Given this list of marker genes WLS, GBP4, DCLRE1C, SMC5, GFI1, LMTK2, STRN4, LIG4, CBFA2T2, MAFB, PTPRF, BTBD7, MYOF, WAPL, SLC37A2, LCA5 (lebercilin LCA5), ATP10A, PLXDC1, CSNK1E, EIF2AK3, HIVEP3, FBF1, CYFIP2, EFCAB8, DUSP5, ARPP21, PLXDC2, SLC16A5, KCNH2, TLK2, PPTC7, ANKRD6, PRRT1 (proline rich transmembrane protein 1), AFTPH, HSF2, MAGI3, DRC12, NFATC2, MCL1, ALG10B, FAM161B, MIER1 (NCBI Gene Id 57708), RMND5A, MYO10, CAB39, MAP3K8, PPT2 (palmitoyl-protein thioesterase 2), TRPM7, TMEM131, CHD6, NHSL1, CD8B, EVI5L, DUSP4, B3GALT2, TACC1, FOXI1, OSBPL11, TPP2, NTN1 (netrin 1), PTPN7, MYLIP, CBLN4, PLAC8L1, PRODH, VARS2, ATP13A3, PARP11, NFKBIE, XRRA1, DAB2IP, TOLLIP, CBFA2T3, ITGA6, GZF1, RAB11FIP4, PFKFB3, CD6, BMAL1, UTP25, BACH1, PAN3, MTSS1, TBC1D2B, CNOT6, ATAD1, KCNJ13, ARID2 (NCBI Gene Id 57676), CEP85, CRYBA1, HS6ST1, STRN3, PPP1R16B, NRIP1, ARL5C, CBL, PTP4A3, NTRK3, RAI1, TTPAL, CD5, RAB5A, TUBE1, VEZF1, SLC38A1, H6PD, ANXA5, USP42, ITGAV, PCF11, FHIP2A, MIR421, DYRK1B, SOCS1 (NCBI Gene Id 8651), AGFG2, CD2AP, MEF2A, TCOF1, DUSP16, NAV2, TCF12, ARHGAP31, BRD4, ZC3H12C (zinc finger CCCH-type containing 12C), TTC13, MAPKBP1, RRAGD, CIDEB, EGLN3, VAMP1, KMT2E, GTF2IRD1, SEC24B, MED14, RALGDS, SMOC1, P2RX1, PFN2, PYCARD, MBNL2, SLC35D1, HDAC9 (histone deacetylase 9), ICAM2, APOBEC2, PSAP, ID3, ENTPD5, QSER1, RNF157, MAP3K1, BFSP2, DGKG, DNAJC6, TMC8, IL18BP, GRIK2, CEP120, SEMA4D, BACH2, CD247, MCAM, here is a description of the gene set: BACKGROUND: Dendritic cells (DC) play a central role in primary immune responses and become potent stimulators of the adaptive immune response after undergoing the critical process of maturation. Understanding the dynamics of DC maturation would provide key insights into this important process. Time course microarray experiments can provide unique insights into DC maturation dynamics. Replicate experiments are necessary to address the issues of experimental and biological variability. Statistical methods and averaging are often used to identify significant signals. Here a novel strategy for filtering of replicate time course microarray data, which identifies consistent signals between the replicates, is presented and applied to a DC time course microarray experiment. RESULTS: The temporal dynamics of DC maturation were studied by stimulating DC with poly(I:C) and following gene expression at 5 time points from 1 to 24 hours. The novel filtering strategy uses standard statistical and fold change techniques, along with the consistency of replicate temporal profiles, to identify those differentially expressed genes that were consistent in two biological replicate experiments. To address the issue of cluster reproducibility a consensus clustering method, which identifies clusters of genes whose expression varies consistently between replicates, was also developed and applied. Analysis of the resulting clusters revealed many known and novel characteristics of DC maturation, such as the up-regulation of specific immune response pathways. Intriguingly, more genes were down-regulated than up-regulated. Results identify a more comprehensive program of down-regulation, including many genes involved in protein synthesis, metabolism, and housekeeping needed for maintenance of cellular integrity and metabolism. CONCLUSIONS: The new filtering strategy emphasizes the importance of consistent and reproducible results when analyzing microarray data and utilizes consistency between replicate experiments as a criterion in both feature selection and clustering, without averaging or otherwise combining replicate data. Observation of a significant down-regulation program during DC maturation indicates that DC are preparing for cell death and provides a path to better understand the process. This new filtering strategy can be adapted for use in analyzing other large-scale time course data sets with replicates. from publication Olex AL, Hiltbold EM, Leng X, Fetrow JS (PMID 20682054) Genes up-regulated in bone marrow-derived dendritic cellstreated by poly(IC): 1h versus 24h. species: Homo sapiens Human Gene Set: GSE21033_1H_VS_24H_POLYIC_STIM_DC_UP